The following is a description of a gene set: Convex nasal ridge Nasal ridge curving anteriorly to an imaginary line that connects the nasal root and tip. The nose appears often also prominent, and the columella low. species: Homo sapiens Human Gene Set: HP_CONVEX_NASAL_RIDGE, and this is the list of marker genes: RUNX2, RNASEH2C, SATB2, C12orf57, PCNT (NCBI Gene Id 9346), SAMHD1, IL11RA, PTF1A, PLK4 (polo like kinase 4), NUP188, ATP6V1E1, ZMPSTE24, NEK9, RMRP, TRAIP, XRCC4, NBN, CREBBP, ZPR1, MBTPS2, ERCC4, LIG4, CCDC22, FGFR3, ERF, TREX1, LRP4, ADAR, LSM11, TWIST1, ATP7A, CPLX1, VPS13B, PLAAT3, LETM1, ASPH, PPP2R3C, MGAT2, MEIS2, DNA2, POLD1 (DNA polymerase delta 1, catalytic subunit), CEP152, CTSK, CENPT, COL1A1, NSD2, SLC2A10, COG4, PEX1, ERCC2, NUP85, DONSON, ELN, LTBP1, TBCE, CSGALNACT1, WRN, CHD6, RBBP8, ATRIP, TRIP13, LEMD2, PDGFRB, LMNA, FGFRL1, ALG9, ZEB2, ASH1L, TAF4, POLR3A, CTBP1, SCARF2, RLIM, DPF2, COL1A2, UBR1, ITCH, PRPS1, COL3A1 (collagen type III alpha 1 chain), APC, RNU7-1, EP300, NHEJ1, CENPE, BANF1, ATR (NCBI Gene Id 57307), EFEMP2, SLC25A24, RNASEH2A, RNASEH2B (NCBI Gene Id 79621), GRIP1, IFIH1, FGFR2 (NCBI Gene Id 2263)